The following is a description of a gene set: Mouse Gene Set: GOBP_PLATELET_AGGREGATION The adhesion of one platelet to one or more other platelets via adhesion molecules. species: Mus musculus, and this is the list of marker genes: Cd9, Syk, Il6ra (NCBI Gene Id 16194), Itgb3, Tubb1, Jak2 (NCBI Gene Id 98155), Comp, Sh2b3 (SH2B adaptor protein 3), Ppia, Pdia4, Pdia2, Serpine2, Tspan9, Ctsg, Mfsd2b, Prkcq, P2ry12 (NCBI Gene Id 73058), Fgg (fibrinogen gamma chain), Tyro3, Gnas, Plek, Prkca, Fgb, C1qtnf1, F11r, Emilin2, Htr2a, Tspan32, Gp6, Cela2a, Alox12, Prkcd, Fermt3, Ubash3a, Stxbp3, Vps33b, Bloc1s4, Wnt3a, Pear1, Ptpn6, F2rl3, Ubash3b, Lyn, Slc6a4, Mmrn1, Il6, Ceacam1, Gla, Pdpn, Tmx1, Stxbp1, Fga, Pdia3, Cfh, Adamts18, Pdgfra, Pdia6, Rap2b, Entpd1, Pip5k1c, Prkg1, Slc7a11, Gata1, Emilin1